Given this list of marker genes Fkbp1b, Ryr2, Bmal1, Smpd3, Slc7a11, Vasn, Clock, Adh5, Npas2, Selenos, here is a description of the gene set: studied in species Mus musculus Mouse Gene Set: GOBP_RESPONSE_TO_REDOX_STATE Any process that results in a change in state or activity of a cell or an organism (in terms of movement, secretion, enzyme production, gene expression, etc.) as a result of a stimulus indicating redox state. Redox state refers to the balance of oxidized versus reduced forms of electron donors and acceptors in an organelle, cell or organ; plastoquinone, glutathione (GSH/GSSG), and nicotinamide nucleotides (NAD+/NADH and NADP+/NADPH) are among the most important.